The following is a description of a gene set: The directed movement of potassium ions from inside of a cell, across the plasma membrane and into the extracellular region. species: Homo sapiens Human Gene Set: GOBP_POTASSIUM_ION_EXPORT_ACROSS_PLASMA_MEMBRANE, and this is the list of marker genes: NEDD4, KCND3, KCNB1, KCNQ1, NPPA, MIR21, KCNK18, KCNK5, KCNIP1, KCNH2, KCNT2, KCNE2, DLG1, KCNA2, WNK4, KCNE1, KCNE4, KCNE3, ANO6, WWP2, KCNIP2, KCNE5, KCNA5, NEDD4L